The following is a description of a gene set: Mouse Gene Set: GOMF_RNA_POLYMERASE_III_TRANSCRIPTION_REGULATORY_REGION_SEQUENCE_SPECIFIC_DNA_BINDING species: Mus musculus Binding to a DNA region that controls the transcription of a gene by RNA polymerase III. Binding may occur as a sequence specific interaction or as an interaction observed only once a factor has been recruited to the DNA by other factors., and this is the list of marker genes: Prdx5, Snapc4, Snapc3, Brf1, Gtf3c5, Mtor, Brf2, Maf1